The following is a description of a gene set: studied in species Homo sapiens AKT phosphorylates targets in the cytosol Human Gene Set: REACTOME_AKT_PHOSPHORYLATES_TARGETS_IN_THE_CYTOSOL, and this is the list of marker genes: MKRN1, CDKN1A, GSK3A, AKT1, AKT2, GSK3B, CDKN1B, AKT1S1, CHUK, AKT3, CASP9, MDM2, TSC2, BAD (BCL2 associated agonist of cell death)